Given this list of marker genes NAB2, POLR2H, CD84, WIZ, RRS1, LCP2, FUNDC2, TRAP1, MTERF3, MOB3C, LINC01128, GAR1, PPP1R14B, RAP1A, GLB1, EED, RRP7A, DNAJA3, GBP2 (NCBI Gene Id 2634), ZNF879, PYCR3, GPATCH4, UBL5, XBP1, MARS2, IDH1, DDX10, INTS6L, ZMYM6, DACH1, ZPR1, RRP1, GGCT, GUCY1B1, IL2RA, PKNOX1, OR7E36P, GLMN, RBM28, SLC26A11, BCAT1, SF3B3, ST8SIA4, SELENOS, URB2, IMMT, CARS1, PSMB5, MLEC, CNIH1, ATXN2, NDC1, SLC39A8, TNF, BYSL, PKIA, CLN6, FTSJ3, ADO, C1orf216, POP1, PER2, TEX30, PRMT1, YWHAE (NCBI Gene Id 7531), POGLUT1, ZNF234, FBXO30, CMSS1, MRPL17, NIPA1, MRPS28, PPP1R10, ISG20L2, RANBP1 (RAN binding protein 1), MRRF, ASNS, C1GALT1C1, CENPBD1P, UBR7, TESPA1, SPAG1, FDX2, GADD45GIP1, ZNF593, BRIX1, TCTN3, DUSP14, PIGM, COA7, MED21, GNL2, ZNF410, TMEM147, PDCD2L, WDR46, ANKS3, VPS35, TAF1A, DSE, SRM, AARS1, NEMP1, RUVBL2, TBL2, BBS12, RAB27A, OSBPL3, TMEM223, B4GALT5, ELP5, SMKR1, ITGB1BP1, RBBP8, EIF2B2 (eukaryotic translation initiation factor 2B subunit beta), MAP7D3, GON7, YARS2, TUBE1, PUS3, PSMD8 (NCBI Gene Id 5714), ABAT, FADD, GEMIN5, CHST11, MAP2K3, POLD2, ERP44, PSMA4, BAHD1, TAF9B, ORMDL2, NCBP1, LPIN2, RNGTT, RALA, CACYBP, DESI1 (NCBI Gene Id 91610), TIAM1 (TIAM Rac1 associated GEF 1), SETBP1, XPOT, MIR17HG, TMEM88, CD200, STAMBPL1, SLC7A1, PHF23, SCO2, NT5E, ACTL10, ZNF235, PSMB2, IFRD2, TMEM126B, MPLKIP, PNO1, AEBP1 (NCBI Gene Id 165), TIMM13, PRPF38A, DNAJC17, BTLA, ELMO3, RAB11A, PUM3 (NCBI Gene Id 9933), GLS, SMG9, SLC5A3, SPINK1, ZNF780A (NCBI Gene Id 284323), PRADC1, TMEM177, STX6, PHLDA1, POLR3D, NAB1, CHST2, TIMM50, NAA20, IRF4, IL1R1, CCDC126, TNFSF11, TXNDC15, RRP9, ANKFY1, PRDX1, WDR36, HOMER1, WDR77, MRPL12, TUBD1, GPN3, SLC25A15, LYST, EPOP, SLC29A1, FYCO1, POLR3H, LTA, here is a description of the gene set: Genes down-regulated in comparison of untreated CD4 T cells at 0 h versus the cells treated with IL4 and anti-IL12 at 4 h. The aim of this dataset was to study in detail the transcription kinetics initiated by cytokine IL-4 in early differentiation of Th2 cells. Human Gene Set: GSE17974_CTRL_VS_ACT_IL4_AND_ANTI_IL12_4H_CD4_TCELL_DN studied in species Homo sapiens from publication Elo LL, Järvenpää H, Tuomela S, Raghav S, Ahlfors H, Laurila K, Gupta B, Lund RJ, Tahvanainen J, Hawkins RD, Oresic M, Lähdesmäki H, Rasool O, Rao KV, Aittokallio T, Lahesmaa R (PMID 20620947)